The following is a description of a gene set: studied in species Homo sapiens The process whose specific outcome is the progression of the epidermis over time, from its formation to the mature structure. The epidermis is the outer epithelial layer of an animal, it may be a single layer that produces an extracellular material (e.g. the cuticle of arthropods) or a complex stratified squamous epithelium, as in the case of many vertebrate species. Human Gene Set: GOBP_EPIDERMIS_DEVELOPMENT, and this is the list of marker genes: CDSN, FGFR2, LORICRIN, PLOD3, TRPC4AP, PTCH1, TGM1, RBPJ, CALML5, STARD7, ZMPSTE24, CSTA, CDKN2A, KRT79, LGR5, KEAP1, MAFG, FLG, LCE3B, PPL, CLDN1, ZNF750, TRIM16, SPRR4, SPRR2B, SGPP1, SEC24B, NGFR, AKR1C3, GRHL2, LCE2A, CASP14, KRT5, FLG2, KLF4, FGF7, ROCK1, LCE7A, LIPM, KRTAP6-1, SPRR2G, BNC1, PITX2, KRT32, KRT78, JAG1, YBX1, EGFR, KRT25, COL7A1, KRT31, LCE3C, DSC1, IL17A, SLITRK6, TFAP2C, TCHH, ATP7A, SFRP4, CST6, REG3A, WNT5A, LCE2B, ETV4, TSG101, WNT10A, DLL1, VDR, KRT9, GNAS, MIR125B1, SCEL, MYO6, PRKCH, SPRR1B, NTF4, LATS2, PIP5K1A, CLRN2, KRT3, LCE3A, CDKN1A, ALOX12, ACVR1B, KLK14, NF1, SLC44A4, STS, GRHL1, FZD6, ABCA12, COL6A1, PTCH2, SOX18, FGF10, NUMA1, HRNR, FERMT1, LCE3E, TRADD, ZDHHC21, CLRN1, IGFBP5 (insulin like growth factor binding protein 5), CYSRT1, YAP1, OVOL3, LCE1F, LDB2, BMP4, HLA-DRB1, ACER1, LHFPL5, KRT17, MET, CNFN, PLAAT4, ST14, GLI2, NAGLU, CYP27B1, KRT86, STRC, EVPL, KRT76, INHBA, PPARD, EMP1, SPRR5, LCE1A, FUZ, PKP3, PTHLH, AGPAT2, SHH, PPHLN1, PAX6, KRT72, CRABP2, TNF, PLS1, TPRN, LCE4A, MANSC4, FLNB, ERCC3, LCE1B, KRT77, FLOT2, GJB5, HOXB13, HOXC13, SAV1, RBP2, KRT84, KRT82, SMAD4, ANKRD24, PDZD7, HDAC2, LCE5A, ALX4, SLC39A7, NAB2, RAC1, WAS, LRP4, OPN3, SPINK5, NSUN2, POU4F3, KRTAP6-2, PIAS4, KLK5, KAZN, TXNIP, EXTL3, KRT74, COL17A1, SPRR2D, KCNQ1, LGR4, ASAH1, CYP26B1, FOSL2, KRTAP5-9, AP3B1, KRT6B, JAG2, FOXN1, TRIOBP, LCE2D, GRXCR1 (NCBI Gene Id 389207), SOX9, KRT10, ALDH3A2 (NCBI Gene Id 224), LSR, SULT2B1, ELAPOR2, KRT6A, ALOX12B, FGF2, SCRIB, GDF3, HDAC1, KDF1, BCL11B, KRT83 (keratin 83), GRXCR2, FOXI3, ESRP1, DNASE1L2, MSX2, ELOVL1, KRT75, GATA6, FST, LCE2C, KRT85, KRT7 (NCBI Gene Id 3855), ATOH1, SHARPIN, DLX3, NOM1, TMEM79, SRSF6, DKK1, KPLCE, SRF, HES1, LHX2, INTU, REG3G, LCE1C, POU3F2, HEY2, SLC4A7, HES5, WNT16, KRT14, LCE3D, NHERF1, PDGFA, MINAR2, STMN1, ALOXE3, FA2H, ZBED2, EXPH5, PAFAH1B1, KRT15, EDA, KRT73, EREG, LCE6A, OVOL2, BCR, LIPK, NFKBIZ, LATS1, NCOA3, POU3F1, ADAM9, EXT1, SMO, IVL, GAL, KRTDAP, ATP2A2, AQP3, REST, KRT4, MCOLN3, KRT81, EDA2R, SOD1, ROCK2, USH2A, SPRR1A, MAP2K1 (NCBI Gene Id 5604), IFT74, RELA, SPRR2E, DCT, POU2F3, CLDN4, FGF20, OVOL1, VANGL2, ANXA1, FOXC1, FZD3, LAMC2, SPRR3, CDH23, IFT172, CERS3, MED1, KRT6C, KRT28, WNT10B, TECTA, GBA1, LCE1D, LDB1, DSP (desmoplakin), TMPRSS11F, MACROH2A2, TMEM132E, WDPCP, ALOX15B, TNFRSF19, SOSTDC1, DKK4, LAMA3, TGFB2, ATP2C1, MYO7A, GORAB (golgin, RAB6 interacting), SVEP1, FOXE1, GSDME, NAB1, MACROH2A1, TGM3, IRF6, KRT1, CD109, HOXA7, SPINT1, KRT16, KRT80, LIPN, GRHL3 (grainyhead like transcription factor 3), PLA2G10, FABP5, KLK7 (kallikrein related peptidase 7), CDH3, KRT36, IL18, INSR, S100A7, IL20, NME2, FOXQ1, PPP3CA, SFN, EZH2, GLI1, SLC39A2, MYSM1, PUM2, KRT27, UGCG, MAFF, ZFP36, TGM5, STK4, TFDP1, ERCC2, ELMOD3, SPRR2F, CTNNB1, PALLD, PLEC, CLIC4, TMC1, EPHA2, KRT71, ZFP36L1, DSG4, KRT34, MYCL, MAFB, LAMA5, FGFR1, TP63, SNAI1, APCDD1, KRTAP6-3, PLOD1, LCE1E, MYCN, WHRN, FAM3C, KRT2, LAMB3, SOX21, HPSE, CCN2, NSDHL (NAD(P) dependent steroid dehydrogenase-like), EDAR, PKP1, HDAC3, SOS1 (SOS Ras/Rac guanine nucleotide exchange factor 1), BCL2, ERRFI1, KLF7 (KLF transcription factor 7), USH1C, PPARA, KPRP, CASP3, NOTCH1